Given this list of marker genes PPT1, BEX4, SIRT3, SIRT7, SIRT5, ABHD12, HDAC10, SIRT1, FRY, ABHD10, PRKAA2, SIRT4, HDAC3, PPT2 (NCBI Gene Id 9374), PRKAA1, NNMT, DESI2, IFNG, ABHD13, ABHD17A, SIRT2, HDAC9, NOTUM, HDAC4, SIRT6, CCAR2, HDAC7, HDAC1, MAPT, FLNA (NCBI Gene Id 8272), DESI1, LYPLAL1, TPPP, CPT1C (carnitine palmitoyltransferase 1C), BRMS1, ABHD17B, ABHD17C, LYPLA1, LYPLA2, HDAC6, EP300, here is a description of the gene set: studied in species Homo sapiens The removal of an acyl group, any group or radical of the form RCO- where R is an organic group, from a macromolecule. Human Gene Set: GOBP_MACROMOLECULE_DEACYLATION